Given this list of marker genes MIF, S100A10, UPP1, MT2A, RALA, S100A8, ADM, SDC2, ANXA1, S100A4, RGCC, SCD, RNASE1, VIM, VCAN (versican), CD52, CSTB, FN1, LGALS3, MT1X, PLIN2, FBP1, ENO1 (NCBI Gene Id 81977), ERO1A, NUPR1, SPP1, CTSL, FABP5, HK2, MT1E, SLC2A1, NDRG1, LDHA, S100A9, SLC2A3, CD9, ANXA2, MARCO, ADAM8, C15orf48 (NCBI Gene Id 84562), S100A6, P4HA1, LGALS1, MT1G, GPNMB, LSP1, APOC1, EMP3, TIMP1 (NCBI Gene Id 7076), BNIP3, here is a description of the gene set: from publication Gavish A, Tyler M, Greenwald AC, Hoefflin R, Simkin D, Tschernichovsky R, Galili Darnell N, Somech E, Barbolin C, Antman T, Kovarsky D, Barrett T, Gonzalez Castro LN, Halder D, Chanoch-Myers R, Laffy J, Mints M, Wider A, Tal R, Spitzer A, Hara T, Raitses-Gurevich M, Stossel C, Golan T, Tirosh A, Suvà ML, Puram SV, Tirosh I (PMID 37258682) In this study, an extensive analysis was conducted to define meta-programs (MPs) capturing intra-tumor heterogeneity across a spectrum of tumor types. The approach utilized non-negative matrix factorization (NMF) to analyze each cell type separately within individual tumor samples. This involved the analysis of malignant cells, macrophages, fibroblasts, endothelial cells, epithelial cells, T-cells, and B-cells. NMF was executed with varying parameter values (K=4, 5, 6, 7, 8, 9), thereby generating 39 programs for each cell type per sample. Each NMF program was summarized by the top genes based on NMF coefficients.\nRobust MPs were then delineated for each cell type using a set of stringent criteria, including recurrence within the same tumor, similarity to programs in other tumors, and non-redundancy within a tumor. Subsequently, these robust NMF programs were clustered (per cell type) based on Jaccard similarity, leading to the identification of MPs associated with each cell type.\nTo enhance the quality of the MPs, a refinement steps were undertaken, involving the removal of MPs suspected of reflecting low-quality data (with an overrepresentation of ribosomal proteins or mitochondrial-encoded genes), single-study inclusion, or similarity to miss-annotated cell types. Human Gene Set: GAVISH_3CA_METAPROGRAM_MACROPHAGES_MES_GLYCOLYSIS studied in species Homo sapiens Genes upregulated in subsets of cells of a given type within various tumors